The following is a description of a gene set: studied in species Mus musculus Chemically induced mouse skin carcinogenesis represents the most extensively utilized animal model to unravel the multistage nature of tumour development and to design novel therapeutic concepts of human epithelial neoplasia. We combined this tumour model with comprehensive gene expression analysis and could identify a large set of novel tumour-associated genes that have not been associated with epithelial skin cancer development yet. Expression data of selected genes were confirmed by semiquantitative and quantitative RT-PCR as well as in situ hybridization and immunofluorescence analysis on mouse tumour sections. Enhanced expression of genes identified in our screen was also demonstrated in mouse keratinocyte cell lines that form tumours in vivo. Self-organizing map clustering was performed to identify different kinetics of gene expression and coregulation during skin cancer progression. Detailed analysis of differential expressed genes according to their functional annotation confirmed the involvement of several biological processes, such as regulation of cell cycle, apoptosis, extracellular proteolysis and cell adhesion, during skin malignancy. Finally, we detected high transcript levels of ANXA1, LCN2 and S100A8 as well as reduced levels for NDR2 protein in human skin tumour specimens demonstrating that tumour-associated genes identified in the chemically induced tumour model might be of great relevance for the understanding of human epithelial malignancies as well. from publication Hummerich L, Müller R, Hess J, Kokocinski F, Hahn M, Fürstenberger G, Mauch C, Lichter P, Angel P (PMID 16247483) Genes up-regulated in benign skin tumors (papilloma) induced by treatment with DMBA and TPA chemicals in the two stage skin carcinogenesis model. Mouse Gene Set: HUMMERICH_BENIGN_SKIN_TUMOR_UP, and this is the list of marker genes: Slpi, Gsto1, Fabp5, Zfp13, Klk9, Usp25, S100a9, Tlcd3a (NCBI Gene Id 76584), Gsta4, S100a8, Drosha, Tgm3, Sprr2a1, Rhog, Sprr2d, Krt16, Krt13, Serpind1, Cyp2c70